Given this list of marker genes Dctn1, Ppp2r5a, Esco1, E2f3, Itgb3bp, Tuba4a, Aurkb, Orc1, Ppme1, Haus7, Tfdp1, Cep63, H3f3a, Psmc2, Tuba1a, Tubb6, Psmb6, Chmp2a, Sumo1, Xpo1, Rfc1, Pola1, H4c1, Prkar2b, Haus1, Optn, Rbl2, H4c6, Psmd12, Prkaca (protein kinase, cAMP dependent, catalytic, alpha), H2bc15, Cep43, Pola2, Mcm7, Ccnb1, Ninl, Psmd7, Kntc1, Mad1l1, Cdkn2b, Psmc3, Prkca, H2bc9, Vrk1, Ankle2, Cep41, Ccnh, Tubgcp6, Rad21, Smc3 (NCBI Gene Id 13006), Cdc6, H3c8, H3c2, Kif2b, Ube2s, Nup42, H4c2, Ccnd1, Gins3 (NCBI Gene Id 78833), Nup54, Sfi1, Mapk3, Lin54, Clasp1, Haus5, Lmna (lamin A), Rbbp4, H2ac22, H4c11, H2ac8, H4c18, Hmmr, Cenpm, Aaas, Dync1li2, Haus8, Pole, H3c4 (NCBI Gene Id 319149), Ppp2r2a, Fzr1, Psmb5, Cdc14a, Rps27a, Nup58, Orc5, Mzt1, Psmc4, H2ac6, Mcm4, H2bc13 (H2B clustered histone 13), Anapc2, Psma6, Kif20a, Cdk4, Cenpa, Pold2, Ran, Pold1, Ccna1, Ticrr, H2ac1, Psmd6, Obi1, H3c6, H3c1, Nudc (NCBI Gene Id 18221), Ndel1, Ist1, Ncapg2, H3c7, Psmc5, Cdk11b, E2f1, Ube2c, H4c12, Cep290, Lmnb1, Bora, H2ax, Phlda1, Vrk2, H4c9, Csnk1e, Cenps, Lin37, Rpa1, Tubgcp3, Cul1, B9d2, H4c8, Cenpt, H2bc12 (H2B clustered histone 12), Lin52, Ube2e1, Cep131, Nup210, Ndc80, Pole2, Ubb, Eml4, Cdkn1c, Cdc7, Ncaph, Ska1, H4c17, Cdkn1a, H2ac23, Anapc7, Nup205, Tubb2b, Cenpe, Ywhae, Tuba1b, Tuba1c, Cc2d1b, Emd, H2az2 (NCBI Gene Id 77605), Ube2d1, H2ac10, Prim1, H2bc8, Ncapd3, Orc4, Cenpq, Sdccag8, Cenpn, Fbxl7, Dbf4, Mad2l1, Psma3, H2bc22, Fkbpl, Nup85, Cdc45, Cables1, H2ac20, Tubgcp2, Nde1, Kif2c, Pcna (NCBI Gene Id 18538), Rae1, Psmc6, Cdkn1b, Psma4, Cep72, Stag1, H2ac19, Cep192, Ppp2r5b, H3c10, Hjurp, H2ac15, Cdc25c, H4c4, H3c15, Dynll1, Tubal3, Rb1, Tubb4b, Psma1, Nedd1, Psmb4, H2bc3, Ccne2, Mcm2, H2ac13, Pold4, Blzf1, Cep152, Psmd13, Anapc10, Cep135, Esco2, Rab1b, H2bc11, Psmd1, Tuba8, Ppp2r1b, Seh1l, Cdc26, Psma7, H2ac12, Tuba3b, Cenpu, Psma5, Ctdnep1, Cep57, Lbr, Kpnb1, Cdk1, Tubb4a, Cenpj, H2bc7, H4c3 (H4 clustered histone 3), Rfc3, Cdc23, Csnk2b, Wee1, Plk1, Orc3, Gins1, H2ac11, Zwilch, H3c11, Gtse1, Psma2, Rab8a, Spc24, Hdac8, Mis12, Ppp2r5d, Lcmt1, H3c13, Gorasp1, H2ac24, H3c3, Nup155, Ccne1, Ndc1, H4c14, Lig1, Mcm8, Gmnn, H2ac7, Dna2, Trp53, Actr1a, Ajuba, Nup133 (NCBI Gene Id 234865), Rab1a, Firrm, H2bc1, Tpx2, H2ac4, Nup93, Psmc1, H2bc27, Golga2 (NCBI Gene Id 99412), Psmb7, Anapc15 (NCBI Gene Id 75430), Chmp2b, here is a description of the gene set: electronically inferred by orthology from the curated human pathway part of: Cell Cycle species: Mus musculus Reactome Pathway: Cell Cycle, Mitotic This event has been computationally inferred from an event that has been demonstrated in another species.<p>The inference is based on the homology mapping from PANTHER. Briefly, reactions for which all involved PhysicalEntities (in input, output and catalyst) have a mapped orthologue/paralogue (for complexes at least 75% of components must have a mapping) are inferred to the other species.